The following is a description of a gene set: Gingival overgrowth Hyperplasia of the gingiva (that is, a thickening of the soft tissue overlying the alveolar ridge. The degree of thickening ranges from involvement of the interdental papillae alone to gingival overgrowth covering the entire tooth crown. studied in species Homo sapiens Human Gene Set: HP_GINGIVAL_OVERGROWTH, and this is the list of marker genes: FGFR2, ABCC9, VPS37D, ZBTB16, FBXO28, BGN, NPM1, KIF7, SC5D, DDR2, KCNMA1, TMCO1, STAT3, GTF2IRD2, KCNK4, REST, RARA, TBL1XR1, GNAQ (NCBI Gene Id 2776), GTF2I, EXTL3, IER3IP1, FIP1L1, ABCA5, TBL2 (transducin beta like 2), FAT4, ATP6V1B2, FZD2, AIMP2, TBC1D2B, CD96, DVL3, CNTNAP1, PRKAR1A, LIMK1, ZEB2, RALGAPA1, SLC17A5, EMC1, AFF3, TBC1D24, VPS13B, DNM1, MGAT2, USP9X, DHCR7, NUMA1, MAN2B1 (NCBI Gene Id 4125), LMNB1, KCNJ6, SLC29A3, LBR, STX1A, GLB1, DVL1, COL3A1, FAM20A, KCNH1 (potassium voltage-gated channel subfamily H member 1), DNAJC30, GTF2IRD1, IDUA, TMEM270, PIGA, TRIM8, ZNHIT3, ANTXR2, SOS1, C1R, RIN2, NEU1, WDR26, OSTM1, PIGS, MMP14, CCBE1, EIF4H, IRF2BP2, NCF1, GUSB (glucuronidase beta), NXN, TBCK, NKX6-2, METTL27, GCSH, STAT5B, ATG7, MYSM1, PLG, AGA, MMP2, NFIX, BUD23, SLC35C1, ANKH, BAZ1B, HIVEP2, ELN (NCBI Gene Id 2006), ASXL3, NABP1, INSR, PML, ROR2, PRMT7, SH3PXD2B, C1S, PIGN, GPC4, IDS, RMRP, CLIP2, KCNN3, FGF3, FAM20C, MAP1B, HYMAI, RFC2, ADAMTS3, WNT5A, ADAMTS2, SATB2 (SATB homeobox 2), BCOR, TWIST2, FKBP6, PLAGL1, GNPTAB, GPC3